Given this list of marker genes RPA1, POLR2B, GTF2H3, UBA52, ERCC4, POLR2J, POLE, RPA2, UVSSA, ERCC8, ERCC6, GTF2H2, UBB, POLR2F, ERCC5 (ERCC excision repair 5, endonuclease), ERCC3, ERCC1 (ERCC excision repair 1, endonuclease non-catalytic subunit), POLD4, POLR2A, POLR2G, XPA, POLE4, CUL4B, POLD1, XAB2, RPS27A, RFC5, RFC4, POLR2L, GTF2H1, CUL4A, RFC2, ISY1, POLE2, POLD2 (NCBI Gene Id 5425), TCEA1, AQR (aquarius intron-binding spliceosomal factor), UBC, POLE3, RBX1, MNAT1, POLR2C, POLR2D, PCNA, CDK7, POLR2E, GTF2H5, DDB1, POLR2K, RFC1 (replication factor C subunit 1), GTF2H4, ZNF830, POLR2I, POLD3, POLR2H, RFC3, USP7, RPA3, PPIE, PRPF19, ERCC2, POLK, CCNH, here is a description of the gene set: Dual incision in TC-NER species: Homo sapiens Human Gene Set: REACTOME_DUAL_INCISION_IN_TC_NER